Given this list of marker genes ALMS1, DYNC1H1 (NCBI Gene Id 992), CEP250, CDK1, HAUS6, CSNK1D, CENPJ, CEP63, NDE1, CNTRL, HAUS8, TUBB4A, NEK2, PCNT, SDCCAG8, CEP135, ODF2, CEP72, MAPRE1, HSP90AA1, CEP78, DYNLL1, AURKA, DYNC1I2, PLK4, PPP2R1A (protein phosphatase 2 scaffold subunit Aalpha), TUBB, HAUS2, CEP290, TUBB4B, NEDD1 (NEDD1 gamma-tubulin ring complex targeting factor), PAFAH1B1, HAUS7, YWHAE, CEP41, CEP43, CEP70, HAUS1, PRKAR2B, CEP152, PRKACA, CCP110 (NCBI Gene Id 9738), TUBA4A (tubulin alpha 4a), NINL, YWHAG, CETN2, CDK5RAP2, HMMR, CSNK1E, CLASP1, SFI1, HAUS3 (NCBI Gene Id 79441), CEP164, AKAP9, PLK1, HAUS5 (NCBI Gene Id 23354), CEP76, TPX2 (NCBI Gene Id 23477), CEP57, CEP192, ACTR1A, OFD1, CKAP5, DCTN1, TUBG1, DCTN2, HAUS4, SSNA1, PCM1, TUBA1A, DCTN3, CEP131 (centrosomal protein 131), here is a description of the gene set: studied in species Homo sapiens Human Gene Set: REACTOME_AURKA_ACTIVATION_BY_TPX2 AURKA Activation by TPX2